The following is a description of a gene set: Mouse Gene Set: GOMF_INTEGRIN_BINDING species: Mus musculus Binding to an integrin., and this is the list of marker genes: Lamb1, Fgf2, Itgb3, Fgf1, Thbs4, Kdr, Cd81, Fermt1, Fermt3, Jaml, Utrn, Itgb8, Adam8, Ptpn2, Itgal, Gsk3b, Lgals8, Vtn, Adam17, Gfra1, Lcp1, Jam2, Itga2b, Adam25, Itgb1, Plpp3, Itga10, Il1b, Vcam1, Timp2, Itgb7, Ilk, Pxn, Mmp14, Madcam1, Itgb2, Itgb5, Lilrb4a, Comp, Itgbl1, Col3a1, Gfap, Itgb6, Adam26a, Cxcl12, Ccn5, Itga1 (NCBI Gene Id 320601), Itga2, Vwf, Itgb1bp1, Cxadr, Itgax, Itga9, Jam3, Mfge8, Slc6a4, Fap, Adam9, Fn1, Itgae, Icam1, Tspan8, Ptn, Cd226, Cdh17, Itgav, Frmd5, Lrp12, Ppia, Emp2, Myh9, Itga3, P4hb, Ibsp, S1pr3, Cd9, Nisch, Cib2, Itga4, Svep1, Igf2 (NCBI Gene Id 16002), Pdia4, Tln1, Thbs1, Src, Thy1 (thymus cell antigen 1, theta), Ptprz1, Ccn6, Nrg1, Dst (NCBI Gene Id 98718), Ccn2, Col4a3, Cd40lg, Sema7a, App, Cx3cl1, Egfr, Adam18, Itga5, Itgb2l, Fbn1, Ccn1, Lamb2, Esm1, Tspan4, Igf1, Cd151, Itga8, Nf2, Gpnmb, Dmd, Icam5, Syk, Calr, Col16a1, Fbln1, Cdh26, Itgad, Ccn3, Itga6, L1cam, Tnn, Spp1, Itgb4, Lyn, Icam4, Dab2, Casr, Lama5, Itgb1bp2, Itgam, Selp (NCBI Gene Id 20344), Tcam1, Anxa7, Ccn4, Prkca, Tln2, Tnc, Cd177, Npnt, S1pr2, F11r, Itga7, Icam2, Ptk2, Hmgb1, Angptl3, Fbln5, Adam15, Actn1, Isg15, Emilin1, Itga11, Tnr, Fermt2, Adam24